The following is a description of a gene set: The process in which the anatomical structures of cartilage are generated and organized. studied in species Homo sapiens Human Gene Set: GOBP_CARTILAGE_MORPHOGENESIS, and this is the list of marker genes: WNT7B, MSX1, HAND2, MATN1, SNAI2 (snail family transcriptional repressor 2), HOXA5, SNAI1, RSPO2, STC1, HAND1